Given this list of marker genes Crk, Ptk2, Actr3 (NCBI Gene Id 74117), Mapk3, Cdc42, Wasf1, Syk, Nckipsd, Arpc2, Actr2, Igll1, Wasf3, Nf2, Vav1, Arpc5, Cyfip2, Arpc4, Grb2, Cd3g, here is a description of the gene set: species: Mus musculus part of: Fcgamma receptor (FCGR) dependent phagocytosis Reactome Pathway: Regulation of actin dynamics for phagocytic cup formation This event has been computationally inferred from an event that has been demonstrated in another species.<p>The inference is based on the homology mapping from PANTHER. Briefly, reactions for which all involved PhysicalEntities (in input, output and catalyst) have a mapped orthologue/paralogue (for complexes at least 75% of components must have a mapping) are inferred to the other species. electronically inferred by orthology from the curated human pathway